Given this list of marker genes GRIA3, PYY, THRA, DNAJB12, GABRE, ALOX15B, PCDHA12, SMARCD2, CYP2C8, ATP9A, ERBB4, GRM8, CXCR2, TOX3, LILRB2, CCR1, DGCR5, DMXL2, PLOD3, MTUS2, IMPG1, MAGEA11, ERBB2, SCHIP1, OR10H3, AHNAK, HSF1, KCTD7, CFD, DTNA, CALCR, KRT4, INPP5A, SLC22A4, CCNB2, BMP6, POU4F1, TPGS2 (tubulin polyglutamylase complex subunit 2), PCDHA3, DIO3, GLA, NR0B2, TMEM8B, NR2F6, ARR3 (NCBI Gene Id 407), AQP2, PTPN3, CDK19, EPB41L1, CAP2, MFAP4, LINC00588, ITGB3, MN1, PCSK5, SEZ6L, ITFG2, SIX3, HCRT, PRORP, PPM1E, PTGDS, UCK2, RUNX2, SASH1, TTLL4, FGF4, AQP6, GNB3, ADORA1 (NCBI Gene Id 134), EIF4G3, CMKLR1, ZBTB5, NR1I2, CAPN9, SRPX, HOXB5, LCN1, TEX28, CPA1, MAPK8IP2, SCAPER, IL17A, ERG, FAM234B, AATK, EIF5A, RNASEH2B, ENTPD2, ZBTB40, RNASE2, TBX19, ATP6V1G2, PHYHIP, AHSG, REG3A, ANK1, TOB2, REM1, RAB27B, PTPRD, SDC3, GP1BA, RAB32, BTK, COL9A2 (NCBI Gene Id 1905), CRX, NRP1, GABRB3, IGFBP1, NALF1, BARX2, ARVCF, BRINP2, SEMA6A, CAMK2A, LEFTY2, WNT4, HYAL3, SULT1C2, KCNH1, STAR, CRAT, RAB30, TMEM30B, PTGS1, CCL1, KRT14, SLC6A1 (NCBI Gene Id 6529), UPK1B, COQ9, IGF2, GSK3A, P2RX5, CYP11B1, ENTREP3, EXTL2, GLRB, CDKL1, GP9, ZDHHC18, HOXB7, B3GAT2, AP3B2, TRIM31, MEOX2, DLG2, KCNMB1, ADGRB3, HMGCS2, TSPAN1, TNP1, ZIC3, PLA2G15, TMCO6, NBR1, CRYGA, CCR9, RAB40C, CXCL1, FLRT2, DUS4L, MVK, GZMH, CLGN, PTPRZ1, STC1, SCNN1A, NID2, PGD, PARP3, FETUB, POLE2, CNNM2, BICD1, RAB11FIP3, SCGB1A1, PROP1, IRX5 (iroquois homeobox 5), EXD2, FBP2, PDZD2 (NCBI Gene Id 23037), FBLN5, TTPA, RHOC, B9D1, HPCA, SLC12A1, CEACAM1, CCL2, KMT2D, PRUNE2, SGCA, ACKR1, ANXA9, HS6ST1, HSD17B8, here is a description of the gene set: The relative contribution of induced and natural Foxp3+ regulatory T cells (iTreg and nTreg cells, respectively) to the maintenance of tolerance is unknown. We examined their respective roles by in vivo adoptive transfer immunotherapy of newborn Foxp3-deficient BALB/c mice. Survival, weight gain, tissue infiltration, T cell activation, and the concentration of proinflammatory cytokines were used as outcome measurements. Treatment with iTreg cells alone was not successful. While effective in preventing death, treatment with nTreg cells alone was associated with chronic inflammation and autoimmunity. Outcomes markedly improved when conventional T (Tconv) cells were transferred together with the nTreg cells, where 10% of the peripheral Treg cell pool was derived by in-situ conversion. This enhancement depended upon the capacity of Tconv cells to express Foxp3. The gene expression profile of in vivo derived iTreg cells was similar to the established nTreg cell genetic signature. These results identify iTreg cells as an essential regulatory subset that supplements tolerance maintained by nTreg cells. from publication Haribhai D, Williams JB, Jia S, Nickerson D, Schmitt EG, Edwards B, Ziegelbauer J, Yassai M, Li SH, Relland LM, Wise PM, Chen A, Zheng YQ, Simpson PM, Gorski J, Salzman NH, Hessner MJ, Chatila TA, Williams CB (PMID 21723159) Human Gene Set: GSE19512_NAUTRAL_VS_INDUCED_TREG_UP Genes up-regulated in T reg: natural versus induced cells. studied in species Homo sapiens